Given this list of marker genes PPP2R5D, PPP2CB, WNT8A, CTNNB1 (catenin beta 1), CSNK1G2 (casein kinase 1 gamma 2), DVL3 (NCBI Gene Id 1857), WNT1, PPP2R5B, CSNK1A1, PPP2R5C, APC, FRAT1, WNT3A, FZD5, PPP2R1A, DVL1, FZD1, PPP2CA, AMER1, FRAT2, AXIN1, PPP2R1B, PPP2R5E, LRP6, GSK3B, WNT8B, DVL2, CAV1, PPP2R5A, FZD2 (frizzled class receptor 2), LRP5, here is a description of the gene set: species: Homo sapiens Human Gene Set: REACTOME_DISASSEMBLY_OF_THE_DESTRUCTION_COMPLEX_AND_RECRUITMENT_OF_AXIN_TO_THE_MEMBRANE Disassembly of the destruction complex and recruitment of AXIN to the membrane